Given this list of marker genes GALK2, ASGR1 (NCBI Gene Id 432), FOXK2 (forkhead box K2), SIL1, ZNF274, ENTPD7, CTSD, PSAP, LINC00511, DPM3, PEX6, COX8A, MPZL3 (myelin protein zero like 3), MMP2, TYROBP, CEP95, UBXN11, SLC9A3-OT1, PLCG1, KIF20B, ZNF23, NOTCH1, FAXC, MUS81, NSMAF, TMEM134, DMAC2L, MEX3D, CLEC14A, ENDOG, SLC30A3, CLUH, PPP1R13B, ARL14EP, PLOD1, POLR2A, PHGDH, MZT2A, PVR, DECR2, SAFB2, FBXL15, TAF10, PMVK, HCFC1, BET1L, ACSS3, SEC13, RPS10P5, THOC6, NOL6, SMG6, TXNRD2, MEDAG, RAB3D, RGS3, RHOF, FZD4, NKAIN1, ISYNA1, CCT3, TNFSF15, CDH16, MSTO1, TNRC6C, SF1, GCHFR, SLC29A1, TRAF4, FAM86C1P, S100A13, DNAAF11, EIF2B5, GMIP, PA2G4, GATA5, MPG, CEP250, TTTY14, AEBP1, WDR87, SDF2, JAG2, NXF2, MACROD1, RPS15, HTT, ACVRL1, SLC16A14, NSUN2, SMAP2, ENPP6, HEXA, MGAT1, CD163, GCAT, MTURN, LIMS2, LYL1, LINC01095, CLSTN1, GBA2, NUP214, SHMT2, NAT9, GABRG3, CBX2, ATP5F1B, CLPB, VPS11, ZFYVE19, CNN1, AIFM2, SLC35C2, F9, RAB40C, PLEKHA8, HYI, CAVIN3, RDH13, LINC02523, PHPT1 (NCBI Gene Id 29085), PSMB5, LGALS1, EXOSC4, PAM16, ZNHIT2, DNPH1, PPP1R14B, ENKD1, MYO7A, EHD2, MCM4, C16orf54, HOXB6, ADGRG1, ANTKMT (NCBI Gene Id 82377), ACE, METTL1, HAX1, WDR4 (NCBI Gene Id 55896), RFLNA, NDUFB10, PNMA2, NLRX1, SNRPC, NOPCHAP1, PXN, EIF6, TGFB3, MAP1B, SEC24C, ISY1, NRF1, PHLDA2, TRO, RAB11FIP3, EIF4EBP1, MLLT1, PYM1, MALL, ZNF268, SEMA3A, GADD45GIP1, TGFBRAP1, OSTCP1, SIRPB2, OLFM4, STOML1, SND1, PXMP2, EXO5, CDR2L, CKAP4, BFSP1, CCS, KCNQ1-AS1, APRT, CAVIN1, IL4R (NCBI Gene Id 3566), BCL6B, MLLT6, SLC2A6, NRCAM, NEDD8, NLRC3, MTG1, TEX264, BCKDHA, P3H4, CCNL2, COL6A2, ZNF296, POLR2L, NADSYN1, SPG7, UPP1 (NCBI Gene Id 7378), here is a description of the gene set: studied in species Homo sapiens from publication Hale JS, Youngblood B, Latner DR, Mohammed AU, Ye L, Akondy RS, Wu T, Iyer SS, Ahmed R (PMID 23583644) Human Gene Set: GSE43863_NAIVE_VS_LY6C_LOW_CXCR5NEG_CD4_EFF_TCELL_D6_LCMV_DN Genes down-regulated in CD4 SMARTA T cells: naïve versus Ly6c low CXCR5- effector during acute infection of LCMV. CD4 T follicular helper (Tfh) cells provide the required signals to B cells for germinal center reactions that are necessary for longlived antibody responses. However, it remains unclear whether there are CD4+ memory T cells committed to the Tfh lineage after antigen clearance. Using adoptive transfer of antigen-specific memory CD4+ subpopulations (based on CXCR5 and Ly6c expression)in the LCMV infection model, we found that there are distinct memory CD4+ T cell populations with commitment to the Tfh and Th1 lineages. Our conclusions are based on gene expression profiles, epigenetic studies and phenotypic and functional analysis. The gene expression profiles of virus-specific CD4 T cell subets at effector and memory stages is presented here.